Given this list of marker genes Stat1 (NCBI Gene Id 98183), Igtp (interferon gamma induced GTPase), Oas1a, Cxcl10, Oasl1, Herc6, Cmpk2, Tcstv4, Parp14, Tdrd7, Tbc1d1, Pml, Lgals3bp (lectin, galactoside-binding, soluble, 3 binding protein), Samd9l, Eif2ak2, Trim25, Ifitm3, Tnfaip1 (tumor necrosis factor, alpha-induced protein 1 (endothelial)), Ifi214, Isg20 (NCBI Gene Id 80487), Hmox1, Gbp2, Usp18, Ifi47, Iigp1, Slfn8, Isg15, Gbp4, Qpctl, Ifit1, Ly6a, Irf7, Rnf213, Trim30a, Samhd1, Ifi204, Trim30d, Ifit3, Nampt, Xaf1, Bst2, Oasl2, Ifi209, Ms4a6b, Ifit3b, Ifi213, Tgtp1 (T cell specific GTPase 1), Zbp1, Irgm1, Dhx58, Gbp9 (guanylate-binding protein 9), Cnnm3, Slfn5, Rsad2, here is a description of the gene set: from publication Cui A, Huang T, Li S, Ma A, Pérez JL, Sander C, Keskin DB, Wu CJ, Fraenkel E, Hacohen N (PMID 38057668) studied in species Mus musculus Mouse Gene Set: CUI_ILC_IFNB_RESPONSE_UP Cytokines mediate cell-cell communication in the immune system and represent important therapeutic targets. A myriad of studies have highlighted their central role in immune function, yet we lack a global view of the cellular responses of each immune cell type to each cytokine. To address this gap, the authors created the Immune Dictionary, a compendium of single-cell transcriptomic profiles of more than 17 immune cell types in response to each of 86 cytokines (>1,400 cytokine-cell type combinations) in mouse lymph nodes in vivo. A cytokine-centric view of the dictionary revealed that most cytokines induce highly cell-type-specific responses. For example, the inflammatory cytokine interleukin-1β induces distinct gene programmes in almost every cell type. A cell-type-centric view of the dictionary identified more than 66 cytokine-driven cellular polarization states across immune cell types, including previously uncharacterized states such as an interleukin-18-induced polyfunctional natural killer cell state. Genes positively differentially expressed in cell type: ILC (innate lymphoid cell) upon treatment with cytokine: IFN-β in mouse lymph nodes in vivo.